The following is a description of a gene set: Mouse Gene Set: MARTINEZ_TP53_TARGETS_UP studied in species Mus musculus from publication Martínez-Cruz AB, Santos M, Lara MF, Segrelles C, Ruiz S, Moral M, Lorz C, García-Escudero R, Paramio JM (PMID 18245467) Genes up-regulated in mice with skin specific knockout of TP53. Squamous cell carcinomas (SCC) represent the most aggressive type of nonmelanoma skin cancer. Although little is known about the causal alterations of SCCs, in organ-transplanted patients the E7 and E6 oncogenes of human papillomavirus, targeting the p53- and pRb-dependent pathways, have been widely involved. Here, we report the functional consequences of the simultaneous elimination of Trp53 and retinoblastoma (Rb) genes in epidermis using Cre-loxP system. Loss of p53, but not pRb, produces spontaneous tumor development, indicating that p53 is the predominant tumor suppressor acting in mouse epidermis. Although the simultaneous inactivation of pRb and p53 does not aggravate the phenotype observed in Rb-deficient epidermis in terms of proliferation and/or differentiation, spontaneous SCC development is severely accelerated in doubly deficient mice. The tumors are aggressive and undifferentiated and display a hair follicle origin. Detailed analysis indicates that the acceleration is mediated by premature activation of the epidermal growth factor receptor/Akt pathway, resulting in increased proliferation in normal and dysplastic hair follicles and augmented tumor angiogenesis. The molecular characteristics of this model provide valuable tools to understand epidermal tumor formation and may ultimately contribute to the development of therapies for the treatment of aggressive squamous cancer., and this is the list of marker genes: Bcap31, Snrnp27, Dnm2, Ak3, Dram2 (DNA-damage regulated autophagy modulator 2), Eml5, Tia1, Kif20a, Capzb, Sprr2d, Lum, Cfl2, Tcf12, Zfr, H2-D1, Septin8, Ntn1, Cep85, Serpina12, Galnt11, Serpinb9c, Nudt7, Ly6d, Epha5, Cfd, Sh3kbp1, Pmepa1, Zfp445, Rab31, Il36g, Srgn, Ccl9, Sgcg, Chchd10, Misp, Pfkfb3, Zfp574, Prokr1, Sigmar1, Ucp3, Thrsp, Pink1, Vps25, Agk, Avpr1a, Gpsm1, Il36rn (interleukin 36 receptor antagonist), Hmga2, Retn, Pea15a, Stom, Ndufs4, Bzw1 (basic leucine zipper and W2 domains 1), Ift46, Akr1c18, Aldh1a7, Dpysl3, Gnas, Clca3a1, Lmbr1, Get3, Trp63, Bicd2, Nsmaf, Aif1l, Npm3, Rsad2, Ctdsp2, Hnrnpll, Ifi203, Ccnd2, Kdm8, Tfrc, Pip5k1a, Gosr2, Washc2, Plac1, Lman1, Jak1, Hdc, Enpp3, Tubgcp2, Zmym4, Cd163, Ddx3y, Ctbs, Ap2a1, Ilf3, Akr1b8, Nadk, Myl4, Fam162a, Papola, Rab2b, Ip6k1, Hadh, Cd74, Babam2, Bcl2l13, Pcsk6, Il36a, Slc14a1, Ltbp1, Wdr45, Mir214, Fuca1, Aqp1, Gm13394, Idh3g, Sncg (NCBI Gene Id 30871), Apoa4 (NCBI Gene Id 11808), Ranbp9, Sox4, Pum1 (NCBI Gene Id 80912), Capn6, Etfrf1, Lxn, Man1a2, Tslp, Cav2, Dram1, Srek1, Rnf114, Serpinb3c, Prkacb, Rab40c, Ccl20, Rnf14, Tpsb2, Ctf1, Mtx1, Ndufaf7, Hipk3, Cab39l, Agpat5 (NCBI Gene Id 68630), Nubp1, Glrx, Osr2, Map1b, Aco1, Alox5ap, Tnfsf14, Recql (RecQ protein-like), Ceacam1, Scoc, Serpinb1a, Suco, Nlk, Car4, Rbp7, Arxes2, Hspa9, Vapb, Cyp11a1, Prkd3, Tceal6, Cyp4b1, Prps1, Ighg2b, Itih5, Btc, Caprin1, Klb, Atpaf2, Snrpn, Tcim, Srpk1, Mob1a, Rilpl2, Zfp330 (zinc finger protein 330), Ccn3, Tpsab1, Hcar2, Rxra, Mrpl3, Rpgrip1, Pigo, Lrrc8c, Vmn1r46, Klra4, Acsl1, Star, Hmgcs2, Rpa1, Il2rg, Tmem222, Myo5b, Acbd3, Abcb8, Inppl1, Spon2, Rps25, Dusp22, Trbc1, Rbbp4 (NCBI Gene Id 19646), S100a8, Tgfbr3, Cox6a1, Tbk1, Set, Sdcbp2, Slc11a2, Tnnt2, Chrnd, Rbms1 (RNA binding motif, single stranded interacting protein 1), Ptgfr, Klk1b27, ENSMUSG00000144058, Ccdc71, Rimoc1, Cma1, Il6st (NCBI Gene Id 71317), Tmem109, Tyrobp, Tcf7, Clec4e, Pitpnb, Dnajb1, Acyp1, Itm2a, Nsun4, Fcgr2b, Zic3, Apoc2, Atxn7l3b, Peg3, Chpt1, Dvl1, Mndal, Rrm1, Timmdc1, Fads2, Acox1, Sod3, Cldn15, Lpl, Psmf1, Eif4h, Skp2, Lce1f, Igf2, Krt77 (NCBI Gene Id 406220), Art3, Tbrg4 (transforming growth factor beta regulated gene 4), Lyz2, Hcfc1, Sar1a, Tgfbr2 (transforming growth factor, beta receptor II), Zc3h11a, Ptpn14, Art1, Ppp3ca, Ap3m1, Spin1, Fbp2, Cxcl14, Cp, Cnot4, Cct6a, Itgav, Tfpi2, Calcoco2, Triap1, Ddx3x, Rfc1, Gna13, Ier3, Cldn11 (NCBI Gene Id 18417), Rgcc, Mapre2, Pbk, Scd2, Gna12, Git2, Trex2, Cars1, Wdr48, Tnfrsf19, Smad5, Mcm6, Nsf, Srek1ip1, Fbxw8, Cxcl12, Snx17, Ikzf1, Nap1l1, Rrn3, Tpp2, Bphl, Pttg1, Laptm4a, Eif4g1, Serp1, Sox11, Rbm6, Cmtr1 (NCBI Gene Id 74157), Pde4dip, Cd36, Psap, Sptbn1, Ms4a6b, Lama2, Usf1, Qsox1, Hoxb6, Klf3 (Kruppel-like transcription factor 3 (basic)), Mr1, Cd44, Tgfbi, Ldhc, Cenpv, Cat, Ube2h, Ushbp1, Esyt3, Ide (insulin degrading enzyme), Cysrt1 (NCBI Gene Id 99256), Pcx, Twsg1, 1810037I17Rik, Alas1, Klhl13, Nnat, Rarres2, Mfap5, Itga9, Acaa2, Mrap, Marchf2, Nabp1, Tmcc2, Myl1, Ndst2, S100b, Rptn, Hbp1, Fech, Prkar1b, Fgl2, Hif3a, Tmem191, Arhgap1, Tmem45a, Opa1, Cav3, Selenof, Hspb7, Dhx40, Bbox1, Slc45a3, Tmem106b, Brat1 (NCBI Gene Id 59292), Tm6sf2, Eif3a, Arpp19, Usp34, H1f2, Wars1, Sppl2b, Sprr2a1, Zfp410, Emp2, Adh1, Sort1, Asb6, Zfp260, Nt5e, Tspan3, Asph, Lrg1, BC028528, Nit2, Pecam1, Abcc5, Fth1, Itga4, Zscan26, Atf2, Gm57857, Arl5a, Lipe, Neu2 (neuraminidase 2), Serpinb2, Tnni1, Kif11, Wee1, Havcr2, Sprr1b, Txnip, Magohb, Rdh10, B2m, Atf3, Fbln1, Cldn10, Gsta2, Ropn1l, Krt6b, Clcf1, Me1, Rxylt1, Rtn4, Ap2b1, Lipa, Cdkn1a, Prdx1, Asb7, Kras, Agtr2, Slc39a3, Pck1, Zbed3, Acad8, Ahr, Ncoa5, Qpct, Hoxb2, Dnpep, Slc4a10, Gpd1, Txndc12, Fah, Fut2, Scube1, Lgals9, Serpinf1, Litaf, Cidec, Dtx3, Fermt3, Trp53inp2, Ykt6, Slc2a4, Atp2a1 (ATPase, Ca++ transporting, cardiac muscle, fast twitch 1), Krtdap, Pitx2, Os9, Fam107b, Immt, Thbs1, Slc48a1, Krt16 (keratin 16), Gstz1, Tcea1, Uqcrb, Pdgfa, Psme4, Sprr2h, Fnta, Npy4r, Il18r1, Cenpb, Pira1, Rnf41, Bmp1, Pld1, Bid, Hbs1l, Cfap97, Coa5, Trib1, Stard4, Ptprf, Sirpa, Pdgfc, Car3, Swsap1, Glo1, Bag4, Ctr9, Dctn4, Saa3, Ly6a, Tshr, Tm6sf1, Cd59a, Spon1, Pdlim5, H2-Aa, Slc25a48, Casp6, Has3, D17H6S56E-5, St3gal2, Eps8l1 (EPS8-like 1), Ubap2l, Angptl2, Dynlt1b, Camk4, Slc6a4, Fgfr2, Lgals1, Etfdh, Pcyt1a, Clns1a, Sec61a2, Cdc42bpa, Ncapd2, Prelp, Arcn1, Pcca, Slc25a13, Cpt1b (NCBI Gene Id 12895), Pja1, Spag5, Slc25a10, Bad, Racgap1, Prr13, Ccn1, Trip13, Celf2, Rad21, Nr3c1, Bnip3, Ms4a6d, Lancl1, Csrp3, Ncoa4, Tnnc1, Tnfaip6, Ltc4s, Tgfb2, Ccdc43, Zfp106, Prmt6, Tmem234, Plek2, Sorbs1, Dgcr2, Gbp2, Ccnl2, Ptgs2, Msra, Esd, Gja1, Cux1, Tes3-ps, Mgat2, Lce1a2, Acta1, Ctla2a, Pex13, App, Xrn2, Pip4k2a, Il1r2, Cdkn1c, Amd-ps1, Tmed9 (transmembrane p24 trafficking protein 9), Cpa3, Iigp1 (NCBI Gene Id 73042), Grb10, Six2, Ucp1, Hoxa9, Ackr1, Chd9, Nr4a1, Slc26a7, Fbln2, Ereg, Lims1, Add3, Add1, Uck1, Ptprg, Ghr, Dlk1, Pon3, Slc35a3, Ubb, Smoc2 (SPARC related modular calcium binding 2), Ptprz1, Eloc, Cldn5, Ifi27l2a, Rabgap1, Sgpl1, Rgs4, C1qb, Arrdc4, Tcap, Ndrg1, Map2 (microtubule-associated protein 2), Lancl2, Lmnb1, Mrc2, Plgrkt, Pnpla2, Ube2d3, Hdlbp, Ckm, Prkce, Ncf2, Slc22a21, Lbp, Kpna6, Lcp1, Ginm1, Ptbp3, Serinc3, Zfp37, Actc1, Gzmb, Gzmg, Car13, Arxes1 (NCBI Gene Id 76219), Slc22a2, Pla2g2f, 9530068E07Rik, Tmem106c, Eri2, Pdpk1, Cacna2d1, Fos, Pilra, Cttn, Hacd3, Morc3, Defb7, Trf, Zfp521, Immp2l, Fabp1, Mef2a, Cpd, Col4a5, Il33, Actb, Msr1, Fscn1, Ints12, Casq1, Ncf1, Nedd4, Lasp1, Dusp1, Pou2f3